Given this list of marker genes PTGS2, ALOX15, ALOX12, ALOX5, here is a description of the gene set: Docosapentaenoic acid (DPA), a C22:5 long-chain ω3 or ω6 polyunsaturated fatty acid (PUFA), is found in algal and fish oils, created via linoleic acid metabolism and is a metabolite in DHA metabolism. It can be acted upon by lipoxygenases to produce mono-, di- and tri-hydroxy derivatives in neutrophils and macrophages. These DPA derivatives are another branch of the specialised proresolving mediators (SPMs) produced from long-chain fatty acids which have anti-inflammatory properties, even though mechanisms of their anti-inflammatory action have not been fully elucidated (Bannenberg & Serhan 2010, Dangi et al. 2010, Vik et al. 2017, Hansen et al. 2017).<br><br>The biosynthesis of SPMs derived from the two isomers of DPA, DPAn-6 (cis-4,7,10,13,16-docosapentaenoic acid) and DPAn-3 (cis-7,10,13,16,19-docosapentaenoic acid), is described here. The only difference between the two isomers is the position of the first double bond; ω-3 for DPAn-3 and ω-6 for DPAn-6. The products of these isomers were characterised by analogy in structure and action to docosahexaenoic acid (DHA)-derived and eicosapentaenoic acid (EPA)-derived resolvins, protectins and maresins. Reactome Pathway: Biosynthesis of DPA-derived SPMs studied in species Homo sapiens part of: Biosynthesis of specialized proresolving mediators (SPMs)